The following is a description of a gene set: Mouse Gene Set: GOBP_EMBRYONIC_HEART_TUBE_LEFT_RIGHT_PATTERN_FORMATION The pattern specification process that results in the subdivision of the left/right axis of the embryonic heart tube in space to define an area or volume in which specific patterns of cell differentiation will take place. studied in species Mus musculus, and this is the list of marker genes: Pitx2, Cited2, Ift122, Invs, Nkx2-5, Cimap3, Megf8